The following is a description of a gene set: Catalysis of the ligation of an acid to an amino acid via a carbon-nitrogen bond, with the concomitant hydrolysis of the diphosphate bond in ATP or a similar triphosphate. species: Homo sapiens Human Gene Set: GOMF_ACID_AMINO_ACID_LIGASE_ACTIVITY, and this is the list of marker genes: TTLL13, TTLL2, GSS, GHDC, GCLC, GCLM (NCBI Gene Id 2730), TTLL5, TTLL3 (tubulin tyrosine ligase like 3), TTLL4, TTL, TTLL1, PPCS, TTLL10, TTLL7, TTLL12, CARNS1, TTLL9, TTLL6, PAICS, TPGS1, TTLL11, TTLL8, FPGS